The following is a description of a gene set: Human Gene Set: HP_SPLENIC_RUPTURE Splenic rupture A breach of the capsule of the spleen. studied in species Homo sapiens, and this is the list of marker genes: GBA1, SCARB2, FGG, FGA, FGB